Given this list of marker genes FBN1, DAND5, MICOS10-NBL1, NBL1, CER1, here is a description of the gene set: Human Gene Set: GOBP_SEQUESTERING_OF_BMP_IN_EXTRACELLULAR_MATRIX Confining a bone morphogenetic protein (BMP) to the extracellular matrix (ECM), such that it is separated from other components of the signaling pathway, including its cell surface receptor. Bone morphogenetic proteins (BMPs) are secreted as homodimers, non-covalently associated with N-terminal pro-peptides, and are targeted to the extracellular matrix through interaction with matrix proteins. studied in species Homo sapiens